The following is a description of a gene set: Human Gene Set: GSE18804_SPLEEN_MACROPHAGE_VS_COLON_TUMORAL_MACROPHAGE_DN Active immunotherapy is a promising strategy for anti-angiogenic cancer therapy. Recently, we have reported that a vaccine using human umbilical vein endothelial cells (HUVECs) induced specific anti-endothelial immune responses in the most of immunized patients, and resulted in tumor regression in some patients with recurrent malignant brain tumors, whereas not in colorectal cancer patients. In this study, we hypothesized that non-hypoxic perivascular tumor associated macrophages (TAMs) in colorectal cancer, but not in glioblastoma, might negatively alter the therapeutic efficacy of anti-angiogenic active immunotherapy. To test this hypothesis, we examined global gene expression profiles of non-hypoxic macrophages stimulated in vitro by soluble factors released from tumor cells of human glioblastoma U-87MG (‘brain TAMs’) or colorectal adenocarcinoma HT-29 (‘colon TAMs’). Genes down-regulated in macrophages: control versus colorectal adenocarcinoma conditioned. species: Homo sapiens, and this is the list of marker genes: TMCC1, AMOT, RNF123, EEPD1, REEP1, USP47, DES (NCBI Gene Id 497658), LPIN1, TEX2, JPH2, SVIP, YWHAE, NEURL1, SUPT3H, KLHDC1 (NCBI Gene Id 122773), GNPAT, PYGM, ZNF2, CDC34, AK1, TRIM54, RYR1, UCP3, STYXL2, NUDT4 (nudix hydrolase 4), SCN4B, KLHL30 (NCBI Gene Id 377007), MLYCD, GGACT, DMD, PACC1, RBM38, ATP13A5, ABCC9, DHX32, SAR1B, TMT1A, CORO6, MLXIP (MLX interacting protein), C11orf86, PRUNE1, FLAD1, SLC49A4, IMMT, CAMK2A (calcium/calmodulin dependent protein kinase II alpha), TMEM117, USP28, UACA, SMARCD3, C4orf54, SMTNL2, PALS1, ZFP2, SMAD3, DELE1, KIAA1217, ALDH1L1, MEF2C, RRAGD, ECI1, TMEM182, HSPB8, PGM1, IPO5, PDZRN4, ESRRG, GUCD1, ART1, TRIP10, DNAJC18, PPM1L, HJV, MLXIPL, TARS3, PLAAT3, CCDC43, FAM83D, IPO13, CUL3, RILP, MYPN, SNAPIN, AARSD1 (NCBI Gene Id 80755), RNF113A, NDUFA10, AS3MT, CAMK2B, SMYD1, CAVIN4, ZC3H8, LSM12, AIP, PPP1R1A, BOD1, FSD2, RBFOX1, CACNA1S, HSPA1L, UBALD1, UQCRC2, FAM170A, POPDC2, ADHFE1, SYNPO2, DNAJB2, MYOZ3, STRADB, COX6A2, MYORG, MTO1, PPM1B, MPP3, PPP1R3C, SMS, STIM1, TMED1, FASTK, RAB12, E2F6, NRAP, SPOCK2, SATB1 (SATB homeobox 1), PPP3CA, KTN1, DRAP1, PLIN4, CSDE1, BTBD1, WWP1, VEGFB, FERMT2, TEAD1, RAPGEF1, AIFM1, ACYP2, PMPCA, ART3, NNT, KCNC4, CHAC1, PRKAA2, NUDT9, PITPNC1, ANKRD37, ITGA10, TBC1D32, LRRC20, PABPC4, OTUD3, PPP1R12B, CNKSR1, SLC38A4, PHTF2, SPEG, SEL1L3, DYNLT1, UNC45B, URGCP, SVIL, FEZ2, TMEM223, ASB14, KIF1B, POPDC3, PFKFB1, H2AC18, SHARPIN, ENO3, ASB12, USP13, BMAL1, MYF6, ST3GAL6 (ST3 beta-galactoside alpha-2,3-sialyltransferase 6), ITGA7, ASB2, MACROD1, PDLIM5, PACSIN3, MAP3K20, TRPT1, MRLN, RILPL1, HACD1, OGFOD3, CDV3, KCNA4, RFK, TPI1, CAMK2G, CHCHD10, ZNF76, PINK1, MAST2, PNPLA2, STYX, RCAN2, DMRT2, RMDN1, CMYA5, ECSIT